Given this list of marker genes Ptpmt1, Glul, Prkn, Mir410, Inhbb, Ptprn, Snord33, Syt9, Sirt1, Bmal1, Ndufaf2, Htt, Ffar1 (NCBI Gene Id 233081), Tiam1, Kcnq1, Acvr1c, Gnaz, Abca12, Snx19, Midn, Ptprn2, Ptprv, Gnaq, Cnr1, Rac1, Cckar, Gper1, Srebf1 (sterol regulatory element binding transcription factor 1), Rbp4, Jak2, Nos1, Ghsr, Capn10, Irs2, Il1b, Lrp1, Ensa, Fto, Mup4, Lep (NCBI Gene Id 16846), G6pc2, Dgat1, Trpm4, Slc8b1, Mup11, Cartpt, Nlgn2, Kcnj6 (NCBI Gene Id 547288), Vgf, Gip, Cftr, Rfx3, Tcirg1, Arrb1, Snap25, Mir200a, Plcb1, Tnf, Mafa, Slc30a8, Jagn1, Slc25a22 (solute carrier family 25 (mitochondrial carrier, glutamate), member 22), Hmgn3, Mup2, Stim1, Mcu, Isl1, Cela2a, Kcnb1, Cpt1a, Lepr (NCBI Gene Id 16847), Pfkm, Il6, Ucn3 (urocortin 3), Alox5, Efna5 (NCBI Gene Id 13640), Sfrp1, Acsl4 (NCBI Gene Id 50790), Blk, Gnas, Sox4, Pick1, Stx1a, Mpc2, Snord32a, Gpld1, Gja1, Gpr27, Atg7, Park7, Pfkl, Cask, Prkcb, Adcy5, Smad2, Hnf1b, Slc9b2, Gnao1, Rfx6, Orai1, Sybu, Rest, Ppard, Ffar2, Ptpn11, Abcg1, Kcnj11, Tcf7l2, Prkar1a (NCBI Gene Id 80472), Mtnr1a, Ccl5, Ildr2, Fam3d, Uqcc2, Rapgef4, Nkx6-1, Mtnr1b, Nr1h4, Ano1, Glud1, Gpr119, Ppp3ca (NCBI Gene Id 99901), Sirt3, Cacna1e, Snord34, Gnai1, Crhr2, Sstr5 (somatostatin receptor 5), Stx4a, Epha5, Hcfc1, Acvr2b, Itpr1 (NCBI Gene Id 18544), Agt, Cplx3, Slc18a2 (NCBI Gene Id 68754), Rph3al, Trpc1, Trh, Lrp5, Tardbp, Nos2, F2rl2, Snord35a, Irs1, Pdx1, Cd38, Gck, Dynll1, F2rl1, Pde8b, Foxa2, Klf7, Map4k4, Bad, Eipr1, Glp1r, Zbed6, Chrm3, Nr1d1, Sri, Rbm4, Nr0b2 (nuclear receptor subfamily 0, group B, member 2), Chga, Serp1, Trpm2, Neurod1, Tfap2b, Hnf4a, Fbn1, Trpa1, Gipr, Gpr68, Ptger3, Myrip, Hadh, Nnat, Gna11, Cacna1c, Drd2, Anxa1, Ptbp1, Piwil4, Hmgcr, Ppp3cb, Rims2, Adra2a, Brsk2, Slc2a2, Prkaca, Ffar3, Ccn3, Bglap2, Anxa7, Sidt2, Mup5, Gprc6a, Hif1a, Sirt6, Sirt4, F2, Cdk16, Osbp, Eny2, Baiap3, Mc4r, Clock, Vsnl1, Rab11fip2, Aacs (NCBI Gene Id 78894), Fkbp1b, Kif5b, Pla2g6, Stxbp4, Trpm5, Stxbp3, Ccdc186, Myt1, Gpr39, Adcyap1, Myh9, Tm7sf3 (transmembrane 7 superfamily member 3), Lrrc8a, Oxct1, Stxbp5l, Tbc1d1, Rab11fip5, Per2, Slc16a1, Ifng, Il1rn, Doc2b, Mir130a, Cltrn, Ghrl, Fam3b, Adcy8, Nadk, Selenot, Fam3a, Cplx1, Birc5, Foxo1, Abcc8 (ATP-binding cassette, sub-family C member 8), Hnf1a, Casr, Pfkfb2, Pde1c, Crh, Pde3b, Tunar, Syt7, Pim3, Cacna1d, Ncoa6, Camk2n1, C1qtnf12, Rab11b, Uts2, Npff, Myo5a, Psmd9, Mup1, Oga, Abat, Mlxipl, Hmga1, Ucp2, C2cd2l, Rab3a (NCBI Gene Id 19339), Cyb5r4, Raf1, Rptor, Prkce, Pck2, Pde4c, Mup3, Sytl4, Gcg, Pclo, here is a description of the gene set: The regulated release of proinsulin from secretory granules accompanied by cleavage of proinsulin to form mature insulin. In vertebrates, insulin is secreted from B granules in the B cells of the vertebrate pancreas and from insulin-producing cells in insects. Mouse Gene Set: GOBP_INSULIN_SECRETION studied in species Mus musculus